The following is a description of a gene set: studied in species Homo sapiens from publication Gao S, Yan L, Wang R, Li J, Yong J, Zhou X, Wei Y, Wu X, Wang X, Fan X, Yan J, Zhi X, Gao Y, Guo H, Jin X, Wang W, Mao Y, Wang F, Wen L, Fu W, Ge H, Qiao J, Tang F (PMID 29802404) Human Gene Set: GAO_SMALL_INTESTINE_24W_C1_TUFT_PROGENITOR, and this is the list of marker genes: CCL2, ARG2, TPM2, IER3, TUBA8, ANAPC1P2 (NCBI Gene Id 285074), NECAP1, ZNF609, HOXA5, GSS, H1-0 (NCBI Gene Id 3005)